Given this list of marker genes Ccr4, Tmem64, Zfp54, Copg1 (NCBI Gene Id 54161), Bicral, EU599041, Gfra1, Hspa13 (heat shock protein 70 family, member 13), Gtsf1, Nom1, Tasor, Magea9, Iho1, Snai2, Cdk12, Oaz2, Nfat5, Clec7a, Aktip, Hdac9, Pex13, Gabra1, Ogfrl1, Zswim6, Kdm7a, Psmf1 (NCBI Gene Id 99294), Il1b, Zfp148, Pcsk5, Tbc1d32, Samd8, Slc8a1, Usp54, Nufip2, Dcx, Vgll3, Nipal3, Acvr2b, Cyyr1, Znfx1, Sec23ip, Zcchc2, Pik3ca, Fam168b, Rspo2, Asxl2, Kcne2, Tomm7, Rpe, Syt14, Rictor, Ercc5, Zfp384, Zwint, Braf, Tfap2a, Slc4a4, Cpsf7, Slc28a2b, Slc28a2, Fndc7, Btn2a2, Pramel27, Bcl2l2, D630045J12Rik, Wrn, Mtcp1, Map3k1, Rpap1, Mpzl2, Kbtbd6, Afdn (NCBI Gene Id 240024), Pter, Lama5 (NCBI Gene Id 99115), Slit2, Wnt3a, P2ry10, Lcorl, Trim33, Gvin3, Carmil1, Nde1, Selenop, Rab11fip2, Ino80d, Emilin3, Ctdspl, Fam168a, Wapl, Clk2, here is a description of the gene set: Mouse Gene Set: MIR_7039_3P Genes predicted to be targets of miRBase v22 microRNA mmu_miR_7039_3p in miRDB v6.0 with MirTarget v4 prediction scores > 80 (high confidence targets). from publication Chen Y, Wang X (PMID 31504780) species: Mus musculus